Given this list of marker genes ITSN2, AP3D1, ITSN1, BTBD8, AP1G1, STX6, VAMP4, RAB11A, EEA1, GRIPAP1, RAB7A, here is a description of the gene set: species: Homo sapiens Human Gene Set: GOBP_SYNAPTIC_VESICLE_ENDOSOMAL_PROCESSING The process in which synaptic vesicles fuse to the presynaptic endosome followed by sorting of synaptic vesicle components and budding of new synaptic vesicles.